Given this list of marker genes TMEM186, WT1, CAMK1G, NKX2-1, PHYH, XPA, IRF6, HLA-DPA1, RBP1, TOMM20, ITFG2, HADH, F11, SFI1, MPPE1, CADM1, ZMYM3, FGF13, GAST, ING1, ADAM22, MPI, ACSM3, UBE4B, ZNF516, RAB22A, SFRP1, CTDSPL, PRODH, TXLNGY, MBNL2, ZC3H4, CAP2, VAMP8, ZMYND10, DOCK2, SF3A3, GPD1L, SEC31A, CLCC1, AQP4, TAL1, NACC2, SERPINA3, AGAP1, SLC33A1, SH3YL1, TCF3, EIF3F, MTA1, ASB1, ARL2BP, SLC24A5, ZRSR2, BTD, SLC5A2, APPBP2, CARTPT, PDCD4, PAGE1, EID1, PAFAH1B3, STAT5B, ARTN, CHP1, ATRX, EZH1, ASAH1, POU1F1, AATK, USP34, HNRNPA0 (NCBI Gene Id 10949), BRS3, TRIB2, TECR, TAF1, TRIM16, INTS3, FHIT, ITGB6, ZNF160, TGIF2, LRRC14, CTNNB1, DDHD2 (NCBI Gene Id 23259), SLC29A2, PEG10, SEPTIN9, TSN, ABCB8, RRP1B, PDK2, CANX, RBM4B, IL10RB, SMARCC1, SV2B, PCSK7, DCP2, SREBF2, PIK3C2A, PALLD, PLP1, CLCN5, NOVA1, IFT140, DOT1L, ASGR1, NDUFV1 (NADH:ubiquinone oxidoreductase core subunit V1), GPR3, SLC16A5, FAM153A, ADH1B, SLITRK2, CAPN3, CRACDL, DBP, SPPL2B, GFRA2 (GDNF family receptor alpha 2), SFN, PLCD1, PCNT, SLC35D1 (solute carrier family 35 member D1), ASXL1, NONO, HSD17B4, SOX4, SUGP2 (NCBI Gene Id 10147), CD72, FAM131B, ELAVL3, PPP3CA, CBR4, TET3, PRKAB2, SLC1A6, SNED1, SYNE1, RPL10, CYP2A7, SRRM2, VEGFD, LIPA, GJA8, RERE, GGA2, ARR3, IL11RA, FOXD1, ADGRB3, SOX12, TTC3, ZHX3, PDXDC1, FAM168B, TPM3, STT3A, SARAF, CPVL, NEFL, NR2F1, CDKL5, LUZP2, CD99, PDIA6, SEC31B, EIF4B, STK38, ZNF623, PHLPP1, MEG3, CNOT9, ADAM12, AP2B1, THOC1, DCAF8, PFDN5, PRKRA, NQO2, TEK, RPS11, FXN, OGT (O-linked N-acetylglucosamine (GlcNAc) transferase), CRKL, PLCL2, RPA1, PLN, NSD2, CD302, HDAC4, GATD3, PXN, RPL39L, CBX7, HSPA1L, HPX, here is a description of the gene set: Genes up-regulated in ex vivo follicular dendritic cells: peripheral lymph node versus Peyers patch. Human Gene Set: GSE19401_PLN_VS_PEYERS_PATCH_FOLLICULAR_DC_UP studied in species Homo sapiens from publication Suzuki K, Maruya M, Kawamoto S, Sitnik K, Kitamura H, Agace WW, Fagarasan S (PMID 20643338) Germinal centers (GCs) are clusters of activated B cells built on stromal cells known as follicular dendritic cells (FDCs). In the Peyer’s patches (PPs), GCs are chronically induced by bacteria and are the major sites for generation of gut IgA immune responses. Whether FDCs directly contribute to the IgA production in PP GCs is unknown. To investigate the role FDCs in gut immune system, we examined comprehensive gene profiles of FDCs purified from PPs or perypheral lymph nodes (pLNs) with or without immunization. We also tried to reconstitute the PP FDC signature in vitro by pulsed or continuous stimulation of pLN FDCs through TLRs, RARs or simultaneously through TLRs and RARs.